Given this list of marker genes Tmprss13, Tm4sf5, Coro6, Gm13547, Cyp17a1, Mmel1, Retn, Slc6a13, Mlc1, Camk1g, Gzma, Trpm2, Mrgprg, Bpifc, Or6e1, Myl2 (NCBI Gene Id 17906), Ppy, Tas2r144 (taste receptor, type 2, member 144), Lyzl6, Nol4l, Or13c7d, Lrrc37, C1qc, Sost, Wfdc21, Krtap10-10, Or1ad1, Car15 (carbonic anhydrase 15), Tg, Or10ak16, Zfp385c, Blnk, Btbd17, here is a description of the gene set: studied in species Mus musculus Mouse Gene Set: MIKKELSEN_MCV6_LCP_WITH_H3K27ME3 Genes with low-CpG-density promoters (LCP) bearing the tri-methylation mark at H3K27 (H3K27me3) in MCV6 cells (embryonic fibroblasts trapped in a differentiated state). from publication Mikkelsen TS, Hanna J, Zhang X, Ku M, Wernig M, Schorderet P, Bernstein BE, Jaenisch R, Lander ES, Meissner A (PMID 18509334) Somatic cells can be reprogrammed to a pluripotent state through the ectopic expression of defined transcription factors. Understanding the mechanism and kinetics of this transformation may shed light on the nature of developmental potency and suggest strategies with improved efficiency or safety. Here we report an integrative genomic analysis of reprogramming of mouse fibroblasts and B lymphocytes. Lineage-committed cells show a complex response to the ectopic expression involving induction of genes downstream of individual reprogramming factors. Fully reprogrammed cells show gene expression and epigenetic states that are highly similar to embryonic stem cells. In contrast, stable partially reprogrammed cell lines show reactivation of a distinctive subset of stem-cell-related genes, incomplete repression of lineage-specifying transcription factors, and DNA hypermethylation at pluripotency-related loci. These observations suggest that some cells may become trapped in partially reprogrammed states owing to incomplete repression of transcription factors, and that DNA de-methylation is an inefficient step in the transition to pluripotency. We demonstrate that RNA inhibition of transcription factors can facilitate reprogramming, and that treatment with DNA methyltransferase inhibitors can improve the overall efficiency of the reprogramming process.